Given this list of marker genes SLC25A31, SLC19A1, SLC25A33, ABCC11, ANKH, SLC25A23, SLC25A41, SLC25A36, SLC25A25, SLC25A52, SLC25A5, SLC25A47 (NCBI Gene Id 283600, solute carrier family 25 member 47), SLC25A6, PANX1, SLC25A24, SLC25A32 (NCBI Gene Id 81034), SLC17A9, SLC25A4, SLC25A42, SLC35B1, LRRC8A, SLC35B3, SLC25A19, SLC25A53, SLC25A17, ABCC5, ABCC4, SLC46A2, SLC35B2, SLC25A51, here is a description of the gene set: Enables the transfer of a nucleotide, any compound consisting of a nucleoside that is esterified with (ortho)phosphate, from one side of a membrane to the other. species: Homo sapiens Human Gene Set: GOMF_NUCLEOTIDE_TRANSMEMBRANE_TRANSPORTER_ACTIVITY